The following is a description of a gene set: Human Gene Set: URS_ADIPOCYTE_DIFFERENTIATION_UP from publication Urs S, Smith C, Campbell B, Saxton AM, Taylor J, Zhang B, Snoddy J, Jones Voy B, Moustaid-Moussa N (PMID 15051823) Uncontrolled expansion of adipose tissue leads to obesity, a public health epidemic affecting >30% of adult Americans. Adipose mass increases in part through the recruitment and differentiation of an existing pool of preadipocytes (PA) into adipocytes (AD). Most studies investigating adipogenesis used primarily murine cell lines; much less is known about the relevant processes that occur in humans. Therefore, characterization of genes associated with adipocyte development is key to understanding the pathogenesis of obesity and developing treatments for this disorder. To address this issue, we performed large-scale analyses of human adipose gene expression using microarray technology. Differential gene expression between PA and AD was analyzed in 6 female patients using human cDNA microarray slides and data analyzed using the Stanford Microarray Database. Statistical analysis for the gene expression was performed using the SAS mixed models. Compared with PA, several genes involved in lipid metabolism were overexpressed in AD, including fatty acid binding protein, adipose differentiation-related protein, lipoprotein lipase, perilipin, and adipose most abundant transcript 1. Novel genes expressed in adipocytes included E2F5 transcriptional factor and SMARC (SWI/SNF-related, matrix associated, actin-dependent regulator of chromatin). PA predominantly expressed genes encoding extracellular matrix components such as fibronectin, matrix metalloprotein, and novel proteins such as lysyl oxidase. Despite the high differential expression of some of these genes, many did not differ significantly likely due to high variability and limited statistical power. A comprehensive list of differential gene expression is presented according to cellular function. In conclusion, these studies offer an overview of the gene expression profiles in PA and AD and identify new genes with potentially important functions in adipose tissue development and obesity that merit further investigation. species: Homo sapiens Genes up-regulated in primary adipocytes compared to preadipocytes., and this is the list of marker genes: LIPC, DPF2, SMARCB1 (SWI/SNF related, matrix associated, actin dependent regulator of chromatin, subfamily b, member 1), PPARG, ALDH1A2, PTPN21, PLIN2, FABP7, DPT, INSR, LRP8, E2F1, MAP4K3, MTUS1, MTMR12, MIR9-1HG, MASP1, ADIPOQ, LPL, FABP4, PTPRZ1, PFKFB3, COL7A1, SKAP1, AMT, PTPRS, CAP2, TFCP2, FXYD1, HSD11B2, APOB, ECM2 (extracellular matrix protein 2, NCBI Gene Id 1842), DGKG, TNFAIP2, CHST1, DGAT1, ACSL1, KCNH2, GPD1, VTN, MMP7, SLC24A2, TAP1, LBP, PLCD1, STAT5B, CTSG, CRYAB, RXRB, ADORA2B, FABP5, PCDH7, ATP2B2, ATP8A2, IGFBP2, PLEK, RXRA, RBIS (ribosomal biogenesis factor), GLUL, APLNR, ABCE1, CIR1 (corepressor interacting with RBPJ, CIR1), AGT, ACOX3, ALDH6A1, USP8